Given this list of marker genes CASQ1, ACTN3, MYOG, FBXO32, DAG1, SCN5A, HDAC4, PIK3CA, here is a description of the gene set: Human Gene Set: GOBP_RESPONSE_TO_MUSCLE_INACTIVITY Any process that results in a change in state or activity of a cell or an organism (in terms of movement, secretion, enzyme production, gene expression, etc.) as a result of a muscle inactivity stimulus. studied in species Homo sapiens